The following is a description of a gene set: studied in species Homo sapiens Human Gene Set: GOBP_REGULATION_OF_EXOCYTOSIS Any process that modulates the frequency, rate or extent of exocytosis., and this is the list of marker genes: VAMP8, P2RX1, WNT7A, BCR, RAPGEF4, SDC4, SDC1, HYAL3, DVL1, FES, NLGN1, IL1RAPL1 (NCBI Gene Id 4399), STXBP5, GIT1, BAIAP3, SYN1, HLA-F, RALA, RAB5A, RAB21 (RAB21, member RAS oncogene family), RAB26, IL13RA2, RIMS4, CEACAM1, UNC13D, LYN, ATP2A2, PRKN, STAM, FBXL20, STXBP2, FOXF1, ZP3, SLC4A8, VSNL1, RAB7A, PREPL (NCBI Gene Id 9581), RAP1A, STX1A, CBARP, RAB33B, HAP1, LGI3, PPFIA2, PDPK1, GNAI2, RIMS1, HGS, PRKCG, LAMP1, TPCN2, EXPH5, ITGB2, MICAL1, CACNB4, RAB15, SNX4, CLASP2 (cytoplasmic linker associated protein 2), RAP1B, DTNBP1, RAB2B, STXBP1, SYT4, SYT3, SV2B, CADPS, RIMS2, IL4R, CDK5, ANXA1, RAP1BL, PRKCB, RAB3B, STX4, CHMP6, SNCA, RAB37, CSPG5, RAB3GAP1, CLASP1 (cytoplasmic linker associated protein 1), FMR1, RPH3A, CCR2, SYT7, ADRA2A, SEPTIN1, PFN2, GPR151, CFTR, F2RL1, SPHK2, CD177, SYT6, FCGR2B, GATA1, PRKCA, C9orf72, SMCR8 (NCBI Gene Id 162633), SNAPIN, FBXO45, SYT2, CPLX1, SEPTIN5, RAB3D, ANXA2, SYT8, RAB3C, ATP13A2, PLA2G3, SYT15, SYTL4, IL13, PRAM1, CPLX2, NPY, PPP3CA (protein phosphatase 3 catalytic subunit alpha), VPS18, ADORA2B, TSG101, DOC2A, DOC2B, NCKAP1L, REST, CD300A, SCAMP5, TRPV6, FGR, CD84, SYT10, NOTCH1, FGB, ADGRE2, CASK, RAC2, RABGEF1, SYK, AP1G1, KCNB1, VAMP7, SYT13, RAB27B, SMPD3, VPS4A, RPH3AL, PCLO, SV2C, FGA, LGALS9, RUFY4, RAB9A, VPS4B, CHMP2A, GAB2, SPI1, CALM3, FGG, IFNG, P2RY1, CADPS2, SYT11, GATA2, SNF8, FCER1G, RAB27A, KLRC2, STXBP6, SYT17, SDCBP, CDK5R2, WDR41, CD160, FERRY3, BRAF, SYT1, STXBP3, RIMS3, VAMP2, SYT12, ATP9A, PDCD6IP, NSF, SYT5, SEPTIN4, CHMP3, ITGAM, S100A10, CPLANE2, RAB3A, LRRK2 (NCBI Gene Id 399472), CACNA1B, SYT9